Given this list of marker genes PPP1R11, NLK, ZNF585B, EPAS1, FBN2, DOCK5, MTNR1B, PKP2, SPTLC1, LYZL1, CDC23, KIF16B, NFIA, SIPA1L1, RMND5A, TRIM58, SCMH1, MAPK9, DNAJA3, CAMK1D, COLEC12 (collectin subfamily member 12), XPO6, ACSL3, ABRAXAS2, CMTM4, ADPGK, AAK1, MIER1, HPCAL4, SYT14 (synaptotagmin 14), TOR2A, TFAP2C, CREB3L1, DNAJC10, KPNA6, ARHGAP35, PIANP, VPS41, FAM220A, ARL4C, FAAH2, HCAR1, CLIP1, RPP14, MFAP2, HNMT, MSR1, ARHGAP44, STMP1, FHIT, ANTXR1, EPS8L3, INHBC, ORMDL2, PRIMA1, IQUB, PLPPR4, PON1, ZBTB20, TAFA2, LYPD3, SUSD1, CSTF3, LNP1, GGT7, LRRFIP2, CDYL2, PEX11B, NRAS, KIF3B, LRRC66, PPP1CB, ZNF444, SRGAP2B, CHAD, DAZ3, MPP7, CAMTA1, LY9, PDE1C, SYT7, PSMF1, RMND5B, COL5A3, ILDR2, KLF7, RNF170, PRIM2, ST8SIA6, ELMO1 (NCBI Gene Id 9844), IFT57 (NCBI Gene Id 55081), ZAR1, KRTAP1-3, IRF6, CYP11B1, KCNA6, CACNA1E, THSD7A, TP63, BSN, RXRB, SCN2B, DEPDC4, ZFHX4, RPGRIP1L, ZMYM3, KRTAP9-3, XPO7, ZFP28, ZDHHC3 (NCBI Gene Id 57245), SYPL2, CHUK, CEP290, PXMP4, CELF3, ARHGEF39, CELF4, RBM43, CDC42SE1, SEPTIN9, ZNF37A, VPS26B, DYNC1I1, COG6, NOVA2, TRPM3, AGO4, KGD4, CD209, INSM2, STARD13, ZNF417, GK5, DAZ1, DHRS3, TAP2, MAB21L1, CARD8, SYNGAP1, AARD, NKD1, ITM2C, PPP6R3, ERAP1, EZH2, FCRL1, CNOT4, HTT (NCBI Gene Id 3064), HDGFL3 (HDGF like 3), TMEM121B, LYZL2, KCNH1, SOBP, SPPL3, NRG2, HEYL, ISCU, WIPF2, ADARB1, KDM5A, IGDCC4, SYN3, LLCFC1, SUDS3, GSTCD, PPP3R2, COX11, MOCS1, SPTLC3, TOLLIP, ARHGEF10, PNKD, ERLIN2, DUSP10, PIK3R1, DAAM2, CACNA2D2, RUNX2, SIX2, COMT, SPATA33, LPGAT1, RNASE13, PAQR9, PIAS2, here is a description of the gene set: from publication Chen Y, Wang X (PMID 31504780) Human Gene Set: MIR6770_5P studied in species Homo sapiens Genes predicted to be targets of miRBase v22 microRNA hsa-miR-6770-5p in miRDB v6.0 with MirTarget v4 prediction scores > 80 (high confidence targets).